Given this list of marker genes Clasp1, Ppp2r1b, Aurkb, Ppp2r5d, Cenpm, Rhob, Pfn1, Tubal3, Cenpe, Mad2l1, Dynll1, Kif2c, Nudc, Tubb2b, Ppp2r5b, Tubb6, Diaph2, Fmnl2, Kntc1, Tuba1a, Cenpa, Spc24, Tuba1c, Kif2b (NCBI Gene Id 73470), Cenpq, Mrtfa, Dvl3, Evl, Seh1l, Nup85, Cenpu, Cdc42, Tuba8, Dync1li2, Plk1, Nde1, B9d2, Xpo1, Ndel1, Dvl2, Nup133, Tubb4b, Tubb4a, Cenpn, Cenpt, Ndc80, Ska1, Itgb3bp, Tuba3b, Dvl1, Tuba1b, Mad1l1, Cenps, Zwilch, Pfn2, Mis12, Tuba4a, Ppp2r5a (protein phosphatase 2, regulatory subunit B', alpha), here is a description of the gene set: electronically inferred by orthology from the curated human pathway studied in species Mus musculus part of: RHO GTPase Effectors Reactome Pathway: RHO GTPases Activate Formins This event has been computationally inferred from an event that has been demonstrated in another species.<p>The inference is based on the homology mapping from PANTHER. Briefly, reactions for which all involved PhysicalEntities (in input, output and catalyst) have a mapped orthologue/paralogue (for complexes at least 75% of components must have a mapping) are inferred to the other species.